Given this list of marker genes ZNF483, SRP19, HPCA, FOXA3, CIART, SLC5A8, HIC2 (HIC ZBTB transcriptional repressor 2), CLDN18, MSLN, TRHR, FLVCR2, GABRR2, UHMK1, SUCNR1, IREB2, RNF2, ARL15 (ADP ribosylation factor like GTPase 15), FSTL3, PPIP5K2, SLC22A18, ZCCHC12, BIK, STARD13, ZPBP2, STPG1, FKBP1B, IGFBP2, MST1R, KCTD13, GFPT1, CALN1, RABGGTB, MIOS, PDE10A, PLA2G10, XK (NCBI Gene Id 7504), PRRT3, RNF180, EPS15, PAPSS2, AGPS, USH1C, APAF1, POLR2M, GATA5, BMP15, SPAST, ZZZ3, CHAT, CES4A, TRDN, POMC, GASK1B, TFRC, RAB26, FABP2, SPHKAP, C9orf72, OCSTAMP, ZNF169, AGXT2, SLC39A6, CER1, SRSF10, S100G, LATS1, SCARF2 (scavenger receptor class F member 2), ARMC3, SLC35E2B, CDC5L, MDFI, OR5P3, CPLX4, WBP2, CPNE2 (copine 2), DUOX1, CCDC77, TARDBP, TMEM50B, HTR7, SUPT3H, SLC30A4, DCTN4, NPAS1, ATL2, ZNF474, FOXB1, PLEKHG1, PCOLCE, CAND1, SLAIN2, DDX4, MAGEB16, CDK8, SAMD1, DGKH, HUS1, DAB2, CDH3, C14orf28, TEX19, MYCT1, NOTCH3, HOXD10, VNN2, IBTK, FBXO16, DYNC2I1 (dynein 2 intermediate chain 1), CYP46A1, ATP7B, TRIM72, IGFBP5, FAT4, B4GALT4, XPO7, GDF5, FHOD1, GPR101, GLMN, EFR3B, NOL3 (nucleolar protein 3), ABHD10, NR2F1, SLC4A1AP, TDRD5 (NCBI Gene Id 163589), FRMPD3, ARFIP1, DKK4, FASTKD5, KCNJ14, TPD52, CTNNBIP1, IFT70A, RPTOR, CCDC89, ACOT1, ATP6V1H, NOP58, SELENOT, FGA, SLC17A7, AKAP1, SPRN (shadow of prion protein), SCRT2, PROM2, UMOD, IGFBP3, TRIB1, ZNF878, TNKS2, FAM111A, SMTNL2, CYB561, MYO1D, TECTB, MS4A13, CHRNA1, HS6ST3, KCNC2, THADA, RASD2, RGS18, MBTPS2, EEF1AKMT2, FZD8, MTFR2, BIRC7, DNAJB6, ZNF597, FNBP1L, GARIN2, MMP16, COL5A2, RTN4RL2, ABHD14B, VAPB, WT1, CHD9, ZC3H12A, SPRY3 (sprouty RTK signaling antagonist 3), HCFC2, SHPK, NRL, PAQR8, PYM1, DMRT3, BAZ2B, KLC2, PCDHB6, IFT81, RAD51B, ATP6V0A1, DOLPP1, CYP17A1, ARPP21, FAM91A1, PTHLH, BMPR1A (bone morphogenetic protein receptor type 1A), CATSPER1, CTRB2 (NCBI Gene Id 440387), here is a description of the gene set: Human Gene Set: GSE28237_EARLY_VS_LATE_GC_BCELL_UP Upon immunization with a T cell dependent antigen naive follicular B cells (Fo) are activated and a germinal center reaction is induced. Within the next 2 weeks large germinal centers develop where the process of affinity maturation takes place. To analyze the gene expression profile of resting and activated B cells, follicular B cells (Fo), B cells from early (GC1) and late germinal centers (GC2) were isolated and their gene expression profile compared. Genes up-regulated in comparison of early germinal center (GC) B cells versus late GC B cells. from publication Wilke G, Steinhauser G, Grün J, Berek C (PMID 20518031) studied in species Homo sapiens